The following is a description of a gene set: Mouse Gene Set: GOCC_UDP_N_ACETYLGLUCOSAMINE_TRANSFERASE_COMPLEX species: Mus musculus A multienzyme, heterooligomeric complex involved in dolichyl-linked oligosaccharide synthesis. In yeast the complex is composed of Alg7p, which catalyzes the first step (GlcNAc1-PP-Dol from dolichol-phosphate and UDP-GlcNAc), and Alg13p plus Alg14p, the catalytic and anchoring subunits respectively, which together catalyze the second step (GlcNAc2-PP-dolichol from GlcNAc1-PP-Dol and UDP-GlcNAc) of dolichyl-linked oligosaccharide synthesis., and this is the list of marker genes: Ugt3a2, Ugt3a1, Alg13, Ext2, Alg14